The following is a description of a gene set: Reactome Pathway: tRNA modification in the nucleus and cytosol At least 92 distinct tRNA nucleotide base modifications have been found. The modifications are made post-transcriptionally by a large group of disparate enzymes located in the nucleus, cytosol, and mitochondria. Modifications near the anticodon and near the 3' end affect interaction of the tRNA with ribosomes and tRNA synthetases, respectively, while modifications in other regions of the tRNA affect folding and stability of the tRNA. Mutations in tRNA modification enzymes are associated with human diseases. part of: tRNA processing studied in species Homo sapiens, and this is the list of marker genes: TYW5, OSGEP, ADAT3, METTL1, QTRT2, WDR4, TRMT1, TPRKB, TYW2, TRMT44, THADA, NSUN6, TRMT13, TP53RK, CTU1, PUS7, LCMT2, CTU2, TRMT5, TYW1, TRMT9B, GON7, EPRS1, NSUN2, CDKAL1, THG1L, TRMT112, TRMT6, TRMT11, QNG1, PUS3, PUS1, FTSJ1, QTRT1, TRDMT1, TRMT10A, URM1, DUS2, ADAT2, TYW3, ALKBH8, TRIT1, LAGE3, ADAT1, TRMT61A